The following is a description of a gene set: electronically inferred by orthology from the curated human pathway studied in species Mus musculus This event has been computationally inferred from an event that has been demonstrated in another species.<p>The inference is based on the homology mapping from PANTHER. Briefly, reactions for which all involved PhysicalEntities (in input, output and catalyst) have a mapped orthologue/paralogue (for complexes at least 75% of components must have a mapping) are inferred to the other species. Reactome Pathway: Metabolism of fat-soluble vitamins part of: Metabolism of vitamins and cofactors, and this is the list of marker genes: Bco2, Lrp10, Apoa2, Rbp2, Gpihbp1, Apoe, Lrp8, Pnlip, Sdc3 (NCBI Gene Id 20970), Sdc1, Apoc3, Akr1c6, Rbp1, Lrp12, Akr1c14, Apoa4, Lpl, Akr1c18, Bco1, Gpc2, Apoa1, Apob, Akr1c21, Akr1b10, Vkorc1l1, Akr1c20, Ubiad1, Apoc2, Ttpa, Vkorc1 (NCBI Gene Id 27973), Akr1c13, Gpc3, Lrp1, Rbp4